Given this list of marker genes TRRAP, CCNE1, NUP188, EIF3A, PDS5A, MYC, BICD2, NCAPD2, ADD3, NSDHL, NDC1, DLGAP5, NBPF14, TUBA3E, UBE2G2, HNRNPR, CERK, DCP2, TIPIN, IMPA2, EIF4G1, TUBA3C, MCM4, TRAF3, ATP8A1, SUPT16H, CTNNA1, SYK (spleen associated tyrosine kinase), ZNF22, CPNE3, HELLS, PRKAR2A, PODXL, PRPF8, CAMSAP1, ZWINT, NCAPH, TACC3, ENO2, CSNK2A1, TFDP1, NCAPG2, CCNA2, HADH, NUSAP1, LYPLA1, SPTBN1, TYMS, PTTG3P, GNB1, AGBL5, OSBPL8, USP7, DDX46, IPO5, CDC7, CUL3, RBBP6, ZFP64, MARCHF6, CNOT1, POLR2B, SCD, CBX3, RNGTT, BIRC5, HDAC9, RAP2A, GINS1, DAZ1, KAZN, AVL9, DSP, CDC42BPA, SLC5A3, PPAT, FAM120A, NAA15, MBNL1 (NCBI Gene Id 9850), HDGF, SMC2 (NCBI Gene Id 10592), BLTP2, DEPTOR, BUB1, HEATR1, PALM2AKAP2, WSB2 (WD repeat and SOCS box containing 2), RFC4, DDAH1, RCAN1, ZC3HAV1, CMPK1, IQGAP1, DROSHA, AP3D1, MCM2, RACGAP1, GMPS, SLC38A2, ZNF395, MYBL2, ALDH5A1, MFHAS1, LPCAT1, CENPF, ELAVL1, CLTC, SLC37A4, RASSF2, CBFB, ACLY, TMEM97, EPRS1, PDS5B (NCBI Gene Id 80197), AKT3, FERMT1, RAB11A, MAPK6, KAT2B, RRM1, MACF1, PPP1R16B, PTTG1, MDN1, HCFC1, TRAM2, TUBB, AHCY, NUP205, MAGED1, PSMD2, SPEN, CALM3 (NCBI Gene Id 808), ASPM, WDR76, TOMM20, KIF14, RAB4A, TPR, MSH2, PDXK, DHCR24, CKAP2, ANKRD10, TRIP13, PIK3CB, CSE1L, ERCC6L, GPRC5A, RSRC1, LBR, NOTCH2, URI1, MYB, PRKDC, NF2, MCM5, MKI67, AKAP11, MMD, EIF4B, SF3B1, FAM20B, SMC3, ARHGAP19, PLEC, FOXM1, PTPN11, POLD3, MAN1A2, SUGP2, EIF2AK2, JPT2, TARDBP, NSD2, PARP1, BUB1B, NFATC2IP, NCAPG, TMEM106C, MELK, HNRNPD, WEE1, CAD (NCBI Gene Id 790), ATP13A3, CBX5 (chromobox 5), DEK, NEK2, MRPL19, NUP50, GPI, EDEM3, ATXN1, CTPS1, GCN1, MTMR4, PCLAF, ECT2, CCNB1, SLC38A1, BLM, FANCI, IMPDH1, KIF4A, RRM2, HJURP, TPGS2, DERL1, PALB2, TOP2A, SLK, KCTD12, CASP6, TBL1X, NUP210, HNRNPAB (heterogeneous nuclear ribonucleoprotein A/B), DUT, NUDT3, AURKA, SKP2, TTC3, KIF18B, EDA, DENND1B, SHCBP1, MSH6, FAM168B, PRKCA, SCAMP1, FBXO5, CDT1, CENPA, SEPTIN9, SNRPA, FUT8, SUMO3, TPX2, PWWP3A, FANCG, CDCA8, CD9 (CD9 molecule), NUCKS1, TEX2 (testis expressed 2), CHAF1A, AGPAT5, GPR161, SLC7A1, CHD4, TOPBP1, PGAM1, here is a description of the gene set: from publication Mitsiades CS, Ocio EM, Pandiella A, Maiso P, Gajate C, Garayoa M, Vilanova D, Montero JC, Mitsiades N, McMullan CJ, Munshi NC, Hideshima T, Chauhan D, Aviles P, Otero G, Faircloth G, Mateos MV, Richardson PG, Mollinedo F, San-Miguel JF, Anderson KC (PMID 18593922) Genes down-regulated in the MM1S cells (multiple myeloma) after treatment with aplidin, a marine-derived compound with potential anti-cancer properties. species: Homo sapiens Human Gene Set: MITSIADES_RESPONSE_TO_APLIDIN_DN Despite recent progress in its treatment, multiple myeloma (MM) remains incurable, thus necessitating identification of novel anti-MM agents. We report that the marine-derived cyclodepsipeptide Aplidin exhibits, at clinically achievable concentrations, potent in vitro activity against primary MM tumor cells and a broad spectrum of human MM cell lines, including cells resistant to conventional (e.g., dexamethasone, alkylating agents, and anthracyclines) or novel (e.g., thalidomide and bortezomib) anti-MM agents. Aplidin is active against MM cells in the presence of proliferative/antiapoptotic cytokines or bone marrow stromal cells and has additive or synergistic effects with some of the established anti-MM agents. Mechanistically, a short in vitro exposure to Aplidin induces MM cell death, which involves activation of p38 and c-jun NH(2)-terminal kinase signaling, Fas/CD95 translocation to lipid rafts, and caspase activation. The anti-MM effect of Aplidin is associated with suppression of a constellation of proliferative/antiapoptotic genes (e.g., MYC, MYBL2, BUB1, MCM2, MCM4, MCM5, and survivin) and up-regulation of several potential regulators of apoptosis (including c-JUN, TRAIL, CASP9, and Smac). Aplidin exhibited in vivo anti-MM activity in a mouse xenograft model. The profile of the anti-MM activity of Aplidin in our preclinical models provided the framework for its clinical testing in MM, which has already provided favorable preliminary results.